The following is a description of a gene set: Binding to a transcription corepressor, a protein involved in negative regulation of transcription via protein-protein interactions with transcription factors and other proteins that negatively regulate transcription. Transcription corepressors do not bind DNA directly, but rather mediate protein-protein interactions between repressing transcription factors and the basal transcription machinery. species: Mus musculus Mouse Gene Set: GOMF_TRANSCRIPTION_COREPRESSOR_BINDING, and this is the list of marker genes: Runx3, Ctnnb1, Stk36, Eno1, Zfp568, Cdc5lrt9, Elob, Suz12, Smad3, Cdc5lrt10, Hdac2, Thap7, Hnf4a, Bcl6, Eed, Smad4, Bsn, Hdac5, Stat1, Ehmt1, Nek6, Eno1b, Lcor, Ezh2, Nr1d1, Six3, Cdc5lrt4, Cdc5lrt7, Per2, Ehmt2, Cnot2, Per1, Wiz, Trp73, Hdac1, Hes1, Phf1, Usp11, Zfp644, Ctbp1, Hdgf, Pbx1, Fam89b, Cdc5lrt8, Mtf2, Trappc2, Eloc, Ets1, Rora, Trappc2b, Cdc37, Atxn3, Lef1, Cdc5lrt1, Per3, Cdc5l, Hdac6, Esr1, Zbtb7a, Cdc5lrt6, Zbtb16, Pclo, Hdac3, Phf12, Runx1, Ctbp2, Cdc5lrt5